Given this list of marker genes PPP1R3F, PPP1R15A, PPP2R3B, PPP1R12A, PPP1R3D, PPP2R2D, WDR82, PPP1R3A, PPP3CA, PPP2R5C, PPP3CB, PPP2R2B, ITPR1, PPP2R3A, PPP2CA, MRAS, PPP2R5D, PPP2R1B, PPP1R3G, IER5, PDP1, PPP2R5A, AKAP5, CTDNEP1, PPP4R4, PPP1R15B, NKD1, PPP4R3B, PDPR, PTPA, TOX4, PPP2CB, PPP4R1, PPP4R3A, PPP2R1A, PPP1R3C, PPP1CB (NCBI Gene Id 5500), PPP1R3E, PPP3R2 (NCBI Gene Id 5535), NCK1, SHOC2, PPP2R2C, PPP1CA, PPP3R1, PPP4C, PPP1CC, PPP2R5B, PPP1R9B, PPP3CC, PPP4R2, PPP4R3C, PPP1R3B, PPP2R5E, CNEP1R1, PPP1R10, PPP2R2A, here is a description of the gene set: species: Homo sapiens A protein complex which is capable of phosphatase activity. Human Gene Set: GOCC_PHOSPHATASE_COMPLEX